Given this list of marker genes RNU12, GADD45B, HOPX, JUNB, CRHBP, H2BC5, MEF2C, CD74, CAVIN2, IER2, SNORD13, H4C5, RNVU1-15, RNU2-3P, H2AC20, SELENOK, APOL3, H2BC21, ZFP36L2, CD69, RNU5A-1, RNVU1-24, SEZ6L2, H1-10, DUSP1, CLEC2B, GNG11, RNU2-5P, LPAR6, JUN, PNRC1, NFKBIA, H2BC7, AVP, CXCL8, EIF4A2, SKAP1, GADD45A, RNU5A-3P, CLEC9A, CD52, HSPA5, RNU2-63P, JAML, NR4A1, HMGA2, MLLT3, RIPK2 (receptor interacting serine/threonine kinase 2), HLA-DRA, H2AC8, HLA-DRB1, TPT1, NFKBIZ, RNU2-14P, BTG2, MECOM, MDK, FOS, ID2, INSIG1, RNU5D-1, ATF3, H2BC8, SPINK2, MYCT1, RNU4-2, RNU5E-4P, LINC00910 (NCBI Gene Id 100130581), RNVU1-6, TUBB4B, OXT, RNU4ATAC, DUSP2, LRBA, RNVU1-19, AREG, RNU5E-1, C12orf57, TRA2B, H1-2, SOCS2, NEAT1, TMEM107, RNVU1-14, HLF, MAFF, MEG3, RNU2-49P (NCBI Gene Id 106480219), RNU5B-1, RNU2-59P, SERTAD4, ZFP36, H1-3, RNU5F-1 (NCBI Gene Id 26828), HLA-DQB1, RNU1-34P, H2BC4, here is a description of the gene set: from publication Zheng S, Papalexi E, Butler A, Stephenson W, Satija R (PMID 29545397) Human Gene Set: ZHENG_CORD_BLOOD_C5_SIMILAR_TO_HSC_C6_PUTATIVE_ALTERED_METABOLIC_STATE studied in species Homo sapiens